The following is a description of a gene set: studied in species Homo sapiens Human Gene Set: GOBP_SYNAPTIC_TRANSMISSION_CHOLINERGIC The vesicular release of acetylcholine from a presynapse, across a chemical synapse, the subsequent activation of dopamine receptors at the postsynapse of a target cell (neuron, muscle, or secretory cell) and the effects of this activation on the postsynaptic membrane potential and ionic composition of the postsynaptic cytosol. This process encompasses both spontaneous and evoked release of neurotransmitter and all parts of synaptic vesicle exocytosis. Evoked transmission starts with the arrival of an action potential at the presynapse., and this is the list of marker genes: CHRNA7, CHRND, RIC3, CHRNB2, ACHE, TACR1, CHRNB4, CHRNA4, LYNX1, LYPD1, CHRNA2, APOE, CHRNG, CHRNA10, LAMA2, CHRNA5, TACR2, ADORA2A, CHRM3, COLQ, CHRNB1 (NCBI Gene Id 1140), ANXA9, NALCN, CHRNA1, SLC5A7, CHRNE, CHRNB3, RAPSN, TAC1, CHRNA6, CHRNA3, SLC18A3, NQO1